The following is a description of a gene set: from publication Chen Y, Wang X (PMID 31504780) species: Mus musculus Genes predicted to be targets of miRBase v22 microRNA mmu_miR_9769_5p in miRDB v6.0 with MirTarget v4 prediction scores > 80 (high confidence targets). Mouse Gene Set: MIR_9769_5P, and this is the list of marker genes: Lrrc15 (NCBI Gene Id 74488), Tmem79, Prkce, Cemip, Bsdc1, Slf2, Fbxo38, Chst10, Atrn, Cdk6, Cacnb1, Nit2, Rnf169, Plpbp, Ogdh, Cetn4, Vps37b, Phldb1, Fndc3b, Tshz1, Neurl1b, Slc39a10, Kif2a, Cblif, Nectin1, Heca, Dgcr2 (NCBI Gene Id 13356), Tmem198, Galnt16, C9orf72, Kcnk4, Sgpp1, Rbm20, Ctdspl, Ints6l, Mindy2, Prpf3, Slitrk3, Spen, Ptpn4, Slc40a1, Eif3b, AA986860, Rreb1, Tbl1x, Tmem170b, Mtor, Hint1, Nr3c2, Trib3, Tanc2, Stk10, Pdcd6, Ppp1r14c, Cdyl2, Mrpl28, Tead3, Rassf8, Tac1, Efna1, Tmem267, Scyl3, Foxo4, Elmo2, Fhl1, Tmem184b, Egr1, Plxna1, Traf3, Ncs1, Cxadr, Plppr4, Sh3kbp1, Cacna1e, Mtcl2, Nek9, Cacng3, Pacsin1, Cc2d1b, E2f5, Gng12, Chic1, Rala, Hook3, Shisal1, Slain1, Plekha5, Arpp19, Gmfb, Ube3a, Mark2, Plxdc1, Zdhhc17, Foxq1, Ss18, Elk4, Fxyd6, Pskh1, Tub, Kdm7a (lysine (K)-specific demethylase 7A), Ppp2r5c, Esrrb, Ccdc121rt3, Gga2, Smo, Mfap3l, Clvs1, Mapkap1, Ahcyl2, Sptbn1, Pfn2, Wrnip1, Aacs, Jpt1, Srsf11, Bltp2, Agxt2, Dgkh (NCBI Gene Id 380921), Alad, Cnot9, Stc1, B4galnt1, Ppbp, Cnnm3, Dcaf10, Lnx2, Mlec, Tpcn2, Prdm16, Mtmr12, Eif6, Mllt10, Iqsec1, Nexmif, Hectd2, Eea1, Alk, Syap1, Tsku, Spink13, 2810459M11Rik, Btbd7, Arhgef18, Thsd7a, Atad3a, Tns3, E2f6, Grm1, Unc5a, Rfx4, Bach2, Nadk2, Galr1, Ppm1g, Lrp6, Itga3 (integrin alpha 3), Pan3, Sp1, Srsf2 (NCBI Gene Id 28128), Cx3cl1, Epha4, Klf3, Tle4, Lpp, Lyrm9, Fundc2, Med1, Tshz3, Prr13, Snx16, St7, P2ry2, Echdc3, Zfhx4, Zkscan17, Hadha, Trappc10, Uck2, Cyrib, Prc1, Sox6, Scamp3, Hacd4, Rab33a, Adam28, Zbtb44, Eci2, Lamc1, Pde7a, Cadm1, Usf3, Pag1, Mast3, Tmed7, Mybpc3, Bean1, Herpud2, Ube2d3, Unc13b, Gpr137, Mxd4, Prrg3, Tafazzin, Hsf5, Plxdc2, Rnf2, Nek2, Chst1, Aak1, Wtip, Mgat4a, Phf6, Ubp1, Krtap3-3, Umad1, Taok1, Cep135, Ccdc121rt2, Pdss1, Rhbdd2, Slc12a6, Ajap1, Rpn1, Mphosph8, Cep97, Irf4, Kcnk10, Gstk1, Syt14, Prrg1, Irx2, Ovol1, Klhl6, Nanos1, Fmr1 (NCBI Gene Id 207836), Qki, Frmd6, Ski, Vtcn1, Abhd4 (abhydrolase domain containing 4), Gpr21, Fggy, Dgkg, 0610040J01Rik, Man1c1, Cep85, 1810024B03Rik, Ptdss1 (NCBI Gene Id 19210), Tlcd5, Dgkk, Cmpk1, Rpia, Tnrc6b, Tmem8b, Rabgap1l